Given this list of marker genes Fgf10, Fgf1, Fgf22, Fgfr1, Gipc1, Fgf2, here is a description of the gene set: species: Mus musculus electronically inferred by orthology from the curated human pathway Reactome Pathway: FGFR1b ligand binding and activation This event has been computationally inferred from an event that has been demonstrated in another species.<p>The inference is based on the homology mapping from PANTHER. Briefly, reactions for which all involved PhysicalEntities (in input, output and catalyst) have a mapped orthologue/paralogue (for complexes at least 75% of components must have a mapping) are inferred to the other species. part of: FGFR1 ligand binding and activation